The following is a description of a gene set: Human Gene Set: GSE45739_NRAS_KO_VS_WT_ACD3_ACD28_STIM_CD4_TCELL_DN It has been recently shown that N-ras plays a preferential role in immune cell development and function; specifically: N-ras, but not H-ras or K-ras, could be activated at and signal from the Golgi membrane of immune cells following a low level TCR stimulus. The goal of our studies was to test the hypothesis that N-ras and H-ras played distinct roles in immune cells at the level of the transcriptome. First, we showed via mRNA expression profiling that there were over four hundred genes that were uniquely differentially regulated either by N-ras or H-ras, which provided strong evidence in favor of the hypothesis that N-ras and H-ras have distinct functions in immune cells. We next characterized the genes that were differentially regulated by N-ras in T cells following a low-level TCR stimulus. Of the large pool of candidate genes that were differentially regulated by N-ras downstream of TCR ligation, four genes were verified in qRT-PCR-based validation experiments as being differentially regulated by N-ras (Dntt, Slc9a6, Chst1, and Lars2). Finally, although there was little overlap between individual genes that were regulated by N-ras in unstimulated thymocytes and stimulated CD4+ T-cells, there was a nearly complete correspondence between the signaling pathways that were regulated by N-ras in these two immune cell types. Since we were interested primarily in genes that were differentially regulated by N-ras following a low-level TCR stimulus, our microarray data comparison was between data from TCR-stimulated, WT CD4+ T-cells and from TCR-stimulated, N-ras KO CD4+ T-cells. Genes that were differentially regulated in the comparison between stimulated N-ras KO CD4+ T-cells and unstimulated N-ras KO CD4+ T-cells, as well as those genes that were differentially regulated in the comparison between stimulated WT CD4+ T-cells and unstimulated WT CD4+ T-cells were excluded from this analysis. To determine if N-ras and H-ras regulate different sets of genes in thymocytes, a comparison was made between the set of genes that were differentially regulated by N-ras in the vs. comparison and the set of genes that were differentially regulated by H-ras in the vs. comparison. Genes down-regulated in activated CD4 T cells: NRAS knockout versus wildtype. from publication Lynch SJ, Zavadil J, Pellicer A (PMID 23755101) studied in species Homo sapiens, and this is the list of marker genes: TMEM230, ADA, ATRAID, APOL3, AMZ2P1, HIPK1, PTPN22, OTUD1, POLI, C1orf21, RBPMS, MUC15, MFSD8, PPCS, MITF, RASGRP4, BTN3A1, APPBP2, MARCHF6, USP9X, MED28, ZNF443, FEZ1, COBL, C2orf74-AS1, ITM2B, PRUNE2, CUTALP, PPM1H, GM2A (ganglioside GM2 activator), RTF1, FUNDC1, CD46, CAPRIN1, ERG28, CD47, JAKMIP2, APAF1, SIKE1, C14orf93 (chromosome 14 open reading frame 93), TRPM6, BRD3, PABPC5, DECR1, CRACD, RFX7, NSMCE2, RNPEP, TXNIP, PECAM1, DENND2B, RB1CC1, IQCG, STAM, FTO, MTARC2, ADNP, SERPINA5 (serpin family A member 5), CCDC86, C9orf40, TPK1, PROK2, GTF2I, CBLN3, KDELR1 (NCBI Gene Id 10945), ARL6IP5, WFDC1, KDM4C, C14orf132, ZNF138, H2AC15, EIF3F, MIS18BP1, THYN1, RIMBP2, MACO1, STRADB, KDM5B, CENPF, IGBP1, PRKD1, GLIDR, RIPOR2, LIPT2-AS1, TIA1, PCMTD1, RACGAP1, TRAFD1, FAM117A, PCBP2, PITPNA-AS1, NBR1, VPS39, ITFG1, F2RL2, SEPSECS, PKHD1, H2BC21, SYF2, NPTX2, NIPSNAP2, SELL, CCDC3, FUCA1, HERC2, ZNF260, SLC6A13, MAX, BCL6, ANKRD13C (ankyrin repeat domain 13C), SH3PXD2A, PARP4, CSAD, HMGN5, CARF, VPS13C, CROT, ATPAF1, TMEM42, BTN3A2, DZIP3, RBM43, KRT10-AS1, SPTBN1, CREB3L4, YTHDC1, OAZ2, UBA3, PBXIP1, PLD1, SGK1, ANO2, LIMA1, CUL4B, HOXC10, STAT2, ENTPD1, ZBTB40, COG4, ARRDC3, RCAN3, BCAR3, UBE2L6, TMOD2, H2AC6, FRA10AC1, PDCD4, ANKRD28, ZNF33B, RNF20 (ring finger protein 20), BRI3, LAMC1, TFDP2, MEGF6, EIF4E3, RTP4, PKIA, GSTZ1, LIAT1, ARHGEF28, DDB2, RNF114, CCNDBP1, IKBKB (NCBI Gene Id 3551), TMEM263 (transmembrane protein 263), SLC16A10, GSTM2, RXFP2, AGPAT4, PTPN13, CCNI, COL15A1, SMYD3, AMZ2 (archaelysin family metallopeptidase 2), FXR1, NEAT1, IFI35, TIFA, ZC3H6, TEP1, KLHL12, WDR72, PPP2R5C, LYSMD3, WBP1L, FAM167A, PYCARD (NCBI Gene Id 29108), KLHDC2, BAZ2B, TOP3B, CFAP20DC, ETS1, GDE1, MARCHF8, ERCC6, DACT1, VPS4B